The following is a description of a gene set: studied in species Homo sapiens Diaphragmatic paralysis Human Gene Set: HP_DIAPHRAGMATIC_PARALYSIS The presence of a paralyzed diaphragm., and this is the list of marker genes: IGHMBP2, MORC2, REEP1, BAG3 (NCBI Gene Id 9531), MEGF10, TPI1, GAA (NCBI Gene Id 2548)